Given this list of marker genes ITPK1, NUDT4, PPIP5K1, IP6K3, IPPK, PPIP5K2, NUDT11, NUDT3, NUDT10, IP6K1, here is a description of the gene set: studied in species Homo sapiens Synthesis of pyrophosphates in the cytosol Human Gene Set: REACTOME_SYNTHESIS_OF_PYROPHOSPHATES_IN_THE_CYTOSOL